Given this list of marker genes CNOT1, ATM, DDX46, TPP2, RAP1A, PRKCSH, FANCG (NCBI Gene Id 82603), LSM12, TAFAZZIN, CLPX, POLR2A, WDR62, EXTL2, IMPA1, PCBP3, UBXN7 (UBX domain protein 7), HMGN4, ZPR1 (ZPR1 zinc finger), CUL2, BAHD1, KATNA1, ERCC2, XPO6, BMS1, EEF1AKMT3, PLIN3, DNAJC7, MARS1, EIF5B, SFSWAP, ADAM15, TRIM27, MGAT1, LAIR1, LDB1, ATP11B, GTF2A2, CPSF4, GLMN, CCT4, MZF1, MLEC, DNAJC8, MFN2, NUDT3, INTS10, MT4, TFAP4, ORC1, SH2B1, TMEM94, KMT2D, SUMO4, ENTREP1, PLPBP, DOK1, THOC2, RERE, ZNF131, GTF2H3, NUP62, HNRNPL, ARID3A, SEC63, HLTF (helicase like transcription factor), B4GALT3, LPIN1, ASH2L (NCBI Gene Id 9070), USP14, EIF4E, PRKAG1, MMS19, RANBP2, HTR7, ARIH2, ZMYM4, PCGF1, RBBP8, CDC7, BMI1, FRYL, TCOF1, ACAP2, GNL2, NFRKB, LANCL1, SEPTIN7, PIGB, PITPNM1, CHD9, CDK11A, KDM3B, SMC5, PKMYT1, CSTF3, PSD4, VARS1, SIK3, PEX3, FRG1, LEPROTL1, RAD54L, RTCA, NDST1 (NCBI Gene Id 3340), P4HA1, IDH3A, NUP188, RFC1 (NCBI Gene Id 5981), POLR2C, here is a description of the gene set: Human Gene Set: MORF_RFC1 Neighborhood of RFC1 replication factor C (activator 1) 1, 145kDa in the MORF expression compendium studied in species Homo sapiens Neighborhood of RFC1